Given this list of marker genes Fam168b, Hsf5, Fzd3, Nfia, Pde6g, Dmc1, Ppp4r3b, Epha3, Lrch3, Arl8b, Birc6, Hspa9, Wipf3, Map3k15, Ifi47, Smn1, Ccdc77, Sfmbt1, Uso1, Ubfd1, Ccr5, Sec63, Bmpr2, Slc39a12, Hip1r, Fcrl5, Havcr2, Traf3, Zfp148, Hmgn3, Pcm1, Bet1, Limd2, Rab37, Prkar2a, Lsm14a, Zfp120, Arih1, Lair1, Armc10, Lpgat1, Hdlbp, St18, Sae1, Prorsd1, Pibf1, Six4, here is a description of the gene set: Mouse Gene Set: MIR_7684_3P from publication Chen Y, Wang X (PMID 31504780) Genes predicted to be targets of miRBase v22 microRNA mmu_miR_7684_3p in miRDB v6.0 with MirTarget v4 prediction scores > 80 (high confidence targets). studied in species Mus musculus